The following is a description of a gene set: studied in species Mus musculus electronically inferred by orthology from the curated human pathway This event has been computationally inferred from an event that has been demonstrated in another species.<p>The inference is based on the homology mapping from PANTHER. Briefly, reactions for which all involved PhysicalEntities (in input, output and catalyst) have a mapped orthologue/paralogue (for complexes at least 75% of components must have a mapping) are inferred to the other species. Reactome Pathway: Downstream signaling of activated FGFR1 part of: Signaling by FGFR1, and this is the list of marker genes: Flrt2, Fgf10, Gab1, Fgf6, Frs2, Hras (Harvey rat sarcoma virus oncogene), Fgf8, Fgf2, Fgf4, Shc1, Grb2, Fgf22, Kl, Flrt1, Fgf17, Fgf5, Fgf1, Fgf23, Fgf20, Fgfr1